Given this list of marker genes Ptprc, Xcl1, Exosc6, Pagr1a, Clcf1, Fcgr3, Lta, Cd28, Il4, Fcer2a, Shld3, Ighg2b, Kmt5c, Il2, Gimap3, Rif1, Cd40, Atad5, Msh2, Trp53bp1, Kmt5b, Tnfsf4, Ifng, Tfrc, Cd226 (CD226 antigen), Tgfb1, Fcer1g, Fcgr1, Mlh1, Trem2, Mad2l2, Hpx (NCBI Gene Id 15458), Tnf, Paxip1, Gimap5, Fcer1a, C3, 6030468B19Rik, H2-T23, Ighg1, Stat6, Btk, Shld1, Tnfsf13, Tbx21, Nsd2, Nod2, Hmces, Exosc3, Shld2, Pms2, Nectin2, here is a description of the gene set: Any process that activates or increases the frequency, rate, or extent of B cell mediated immunity. Mouse Gene Set: GOBP_POSITIVE_REGULATION_OF_B_CELL_MEDIATED_IMMUNITY species: Mus musculus